The following is a description of a gene set: studied in species Homo sapiens The aggregation, arrangement and bonding together of a cytochrome complex. A cytochrome complex is a protein complex in which at least one of the proteins is a cytochrome, i.e. a heme-containing protein involved in catalysis of redox reactions. Human Gene Set: GOBP_CYTOCHROME_COMPLEX_ASSEMBLY, and this is the list of marker genes: TTC19, UQCC5, STMP1, UQCC6, CYBA, UQCRFS1, MT-CO3 (NCBI Gene Id 4514), COA1, LYRM7 (LYR motif containing 7), CEP89, HCCS, TMEM223, SCO2, PET100, UQCC2, TIMM21, UQCC1, COA7, TACO1, COX18, UQCC3, COX15, COA4 (NCBI Gene Id 51287), COA5, UQCC4, PET117, SCO1, COX10, COX20, SLC25A33 (solute carrier family 25 member 33), FXN, COX17, COA8, COA3, COA6, COX19, SLC25A46, COX16, SURF1, FASTKD3, BCS1L, SMIM20, COX14